Given this list of marker genes TBX3, BMP4, GLI3, TBX2, FGFR2, FGF10, NRG3, here is a description of the gene set: The process pertaining to the initial formation of the mammary gland from unspecified parts. The process begins with formation of the mammary line and ends when the solid mammary bud invades the primary mammary mesenchyme. species: Homo sapiens Human Gene Set: GOBP_MAMMARY_GLAND_FORMATION